Given this list of marker genes TICAM1, TICAM2, IKBKG (NCBI Gene Id 8517), TRAF6 (TNF receptor associated factor 6), UBE2D2, TLR4, RPS27A, UBE2N, UBE2V1, UBB, BIRC2, RIPK1, UBE2D3, LY96, CD14, IKBKB, RIPK3, CHUK, UBA52, UBE2D1, SARM1, BIRC3, UBC, here is a description of the gene set: Reactome Pathway: IKK complex recruitment mediated by RIP1 part of: TRIF (TICAM1)-mediated TLR4 signaling  Receptor-interacting protein 1 (RIP1) mediates the activation of proinflammatory cytokines via intermediate induction of IKK complex in NFkB pathways. Poly(I-C) treatment stimulated the recruitment of RIP1, TRAF6, and TAK1 to the TLR3 receptor complex in human embryonic kidney HEK293 transfected with FLAG-tagged TLR3. RIP1 was shown to be dispensable for TRIF-dependent activation of IRF3, which occurs in a TRIF/TBK1/IKKi-dependent manner studied in species Homo sapiens